Given this list of marker genes GPI, ZFYVE26, ZC3H7B, PDP2, PTAR1, CEP83, CYP1A2, DDX31, USP8, GRK3, TMPO, SZRD1, LYPD5, ZNF587, GPR156, SGPL1, CRIPT (NCBI Gene Id 9419), TMEM132D, PMP2, KCNJ10, SLC11A2, NOMO3, PAX6, NDUFAF5, FAM86C1P, LEPR, ANK1, SGSM1, AUNIP, SPAG17, UTP25, DCD, PRMT5, RFTN2, FEN1, MTMR3, NKTR, CORO2B, ABI1, FBXL20 (NCBI Gene Id 90110), CHST3, NBPF11, PIP4K2B, IKZF3, NRIP3, CHMP5, ABCD3, CA10, F2RL2, PDK3, SLC44A1, ZZEF1, NRP2, S100A7A, ZC3H4, KPNA1, MOCS2, COQ5, XK, ZNF814, XPO1, ERCC6L2 (ERCC excision repair 6 like 2), ONECUT2, ORAI2, IMPA1, HOGA1, MAVS, TNFRSF1B, CHST11, MEAF6, IKBKE, KIR2DL4, IGF2R, NALF2, HOOK3, NOMO2, HIF3A, MMP24, SPOCK2, LRRC51, SAMD4B, PMAIP1, MBNL3, CCDC174, SCAI, GJC1, AFF4, PMS1, IGLON5, MDM2, GFRA1, FBXW2, TBC1D20, LAMP3, GNPNAT1, EIF4E3, ZFTA, GPR15LG, NBPF3, GRB10, FAM20B, SLC10A7, KRT10-AS1, PARVA, PIK3AP1, COPS7B, ZNF281, CLVS1, CDC23, KCNMA1, GORASP2, TRAPPC2, EEF2K, FKBP4, TNFRSF10B, STAG3, OLFML1, GTF3C1, ATM, CBX5, NOMO1, IL13, ACVRL1, GABRB2, SLA2, ALS2, MTCL2, PSD3, MARCHF6, NBPF20, EVI5, PRKCA, VTA1, HMCN1, NBPF8, UNC5D, ABCC1, MCFD2, MTREX (NCBI Gene Id 23517), ZNF850, SF3B1, PRUNE1, RAB3IP, TBC1D24, EGFR, DCAF16 (DDB1 and CUL4 associated factor 16), NBPF1, CERS6, OTUD4 (OTU deubiquitinase 4), PLEKHA6, SEC24B, GNB4, ZBTB8A, THRB, C4orf3, NBPF14, NBPF9, MTMR4, SF3B3, TMCC3, HMGCS1, ETV6, CYP20A1 (cytochrome P450 family 20 subfamily A member 1), CDADC1, IRGQ, SRRM4, KRT75, APOBEC3F, LHCGR, KCNB1, NBPF12, SRGAP1, DYNLL1, MED14 (mediator complex subunit 14), RPN1, NBPF15, COL21A1, MICAL2, PAX7, SUCLG1, XPNPEP3 (X-prolyl aminopeptidase 3), RBMS3, ADGRG5, KRTAP24-1, MDM4 (MDM4 regulator of p53), RAPGEF5, here is a description of the gene set: from publication Chen Y, Wang X (PMID 31504780) Human Gene Set: MIR4478 species: Homo sapiens Genes predicted to be targets of miRBase v22 microRNA hsa-miR-4478 in miRDB v6.0 with MirTarget v4 prediction scores > 80 (high confidence targets).